Given this list of marker genes TRIM14, ODC1 (NCBI Gene Id 4953), HDGF, FBL, TFDP1, EIF1AX, FTSJ1, SRRM2, UCHL3, BYSL, PDIA5, SYNCRIP, MRPL19, RPP40, PMM2, PAICS, HSPA9, AMD1, SRPK1, TIMM17A, CEBPZ, EXOSC7, MYC, IRAK1, FABP5, RAN, PPAT, DDX21, PRNP, RSL1D1, ADCY3, LDHA, URI1, DKC1, EBNA1BP2, BAG2, PRDX4, PA2G4, UTP18, NCL, RPIA, CSE1L (chromosome segregation 1 like), AKAP1, MXI1, CUL1 (NCBI Gene Id 8454), NOP14, RRS1, THAP12, here is a description of the gene set: from publication Schlosser I, Hölzel M, Hoffmann R, Burtscher H, Kohlhuber F, Schuhmacher M, Chapman R, Weidle UH, Eick D (PMID 15516975) Human Gene Set: SCHLOSSER_MYC_TARGETS_AND_SERUM_RESPONSE_DN Cluster 6: genes down-regulated in B493-6 cells (B lymphocytes) by MYC in combination with serum but not affected by serum alone; they are also up-regulated by MYC alone. Proliferation of higher eukaryotic cells is triggered by the proto-oncogene c-myc (myc), which is induced downstream of a large number of growth factor receptors. Myc, a basic helix-loop-helix leucine zipper transcription factor, transmits growth signals by up- and downregulation of target genes. The importance of Myc in growth control is well established. However, the number of growth control genes requiring Myc as an essential factor for regulation after mitogenic stimulation of cells is not yet clear. Here, we have studied the transcriptional programme of a human B-cell line, P493-6, in response to Myc and serum. P493-6 cells do not express the endogenous myc, nor is it induced by serum stimulation. Proliferation of the cells is dependent upon both the expression of a tetracycline-regulated myc gene and serum stimulation. Using DNA microarrays, expression profiling was performed following stimulation of cells with serum, with Myc, or with both. We observed serum regulation of >genes. A number of these genes were synergistically or antagonistically regulated by Myc. Moreover, we identified >300 Myc-regulated genes that were almost unresponsive to serum. Gene ontology analysis revealed that a high proportion of Myc target genes are involved in ribosome biogenesis and tRNA metabolism. The data support our current notion that Myc is essential for the regulation of a large number of growth-related genes in B cells, and cannot be replaced by other serum-induced factors. studied in species Homo sapiens